Given this list of marker genes ECM1, APOE, GADD45A, DDIT4, COL18A1, H1-2, ENPP2, MAGEH1, TGFBI, KRT13, HMOX1, MMP13, RBP4, here is a description of the gene set: The tumor suppressor protein BRCA1 has been shown to enhance p53 transcription, whereas activated p53 represses BRCA1 transcription. To further understand the functional interaction of these proteins, we investigated the role of BRCA1 in p53-induced phenotypes. We found that BRCA1 when subjected to forced expression acts synergistically with wild-type p53, resulting in irreversible growth arrest, as shown by VhD mouse fibroblast cells expressing a temperature-sensitive mutant of p53. Furthermore, reintroduction of both BRCA1 and p53 into BRCA1(-/-)/p53(-/-) mouse embryonic fibroblasts markedly increased the senescence phenotype compared to that induced by p53 alone. In particular, we found that BRCA1 expression attenuated p53-mediated cell death in response to gamma-irradiation. Moreover, microarray screening of 11 000 murine genes demonstrated that a set of genes upregulated by p53 is enhanced by coexpression of BRCA1 and p53, suggesting that BRCA1 and p53 exert a promoter selectivity leading to a specific phenotype. Taken together, our results provide evidence that BRCA1 is involved in p53-mediated growth suppression rather than apoptosis. studied in species Mus musculus Genes up-regulated in MEF cells (embryonic fibroblast) lacking TP53 and BRCA1 by expression of BRCA1. Human Gene Set: ONGUSAHA_BRCA1_TARGETS_UP from publication Ongusaha PP, Ouchi T, Kim KT, Nytko E, Kwak JC, Duda RB, Deng CX, Lee SW (PMID 12802282)